The following is a description of a gene set: Genes down-regulated in CD8 T cells: naïve versus memory at day 30 after acute infection with LCMV-Armstrong. During acute viral infections, naïve CD8+ T cells differentiate into effector CD8+ T cells and, after viral control, into memory CD8+ T cells. Memory CD8+ T cells are highly functional, proliferate rapidly upon reinfection and persist long-term without antigen. In contrast, during chronic infections, CD8+ T cells become “exhausted” and have poor effector function, express multiple inhibitory receptors, possess low proliferative capacity, and cannot persist without antigen. To compare the development of functional memory T cells with poorly functional exhausted T cells, we generated longitudinal transcriptional profiles for each. studied in species Homo sapiens from publication Doering TA, Crawford A, Angelosanto JM, Paley MA, Ziegler CG, Wherry EJ (PMID 23159438) Human Gene Set: GSE41867_NAIVE_VS_DAY30_LCMV_ARMSTRONG_MEMORY_CD8_TCELL_DN, and this is the list of marker genes: POC5, MTO1, CWF19L1, PGM3, PAQR3, BOLA3, LONP1, EIF4H, FANCB, POLR2B, ZBTB32, AGK, VPS72, SGTA, POLR2K, RUFY1, PLEKHA3, PCMT1, TIPIN, SUMF2 (NCBI Gene Id 25870), API5, PDLIM1, PTBP1, KIAA1191, TAF1C, SLC25A1, RBMXL1, PSMD12, OLA1, RFK, MOSMO, RCCD1, LYRM1 (LYR motif containing 1), FMC1, BAG4, SETDB1, ATP23, PRORP, RCC2, CCDC51, CD44, ALG3, FBXO28, COPS2, DENND4C, LIG1, LRP6, PELP1, MSANTD4, UBE2G2, SDR39U1, LDAH, CFAP298, NETO2, DUS1L, FASTKD2, GCLC, PTPN12, PSMC1, CDC34, REPIN1 (NCBI Gene Id 96712), DHRS13, PCYT1A, SNRPD1, TRIP10, BOLA1, MPHOSPH8 (M-phase phosphoprotein 8), MAGOH, MMGT1, CCDC59, PREP, COX11, DNAJC27, FAM241A (family with sequence similarity 241 member A), CTNNAL1, NDUFS3, PINX1, NOL10, TXN, RBIS, PLXND1, DYNC1LI1, CDC73, BCAS2, NUP42, MARCKSL1 (MARCKS like 1), UBE2J2, AKR1B1, DDX19A, EMD, GAN, GPHN, ECE2, PTGES2, HAUS7, SLF1, MTF1, LTA4H (leukotriene A4 hydrolase), NPLOC4, TMEM147, SLC7A6OS, ANAPC4, ZNF490, DNAJA2, MCMBP, RINT1, RNMT, TANGO6, POM121, CDK17, CCDC171, EFTUD2, NIBAN1, KLHDC10, AMMECR1 (NCBI Gene Id 9949), CHORDC1, ME2, ADRA1A, HGH1, INTS8, SEMA7A, SGSM3, OTUD6B, OGDH (oxoglutarate dehydrogenase), SEC23IP, DUSP16, NAA10, POMP, POLR1F, ZWILCH, KPNA4, THAP4, DCPS, METRN, UBE2M, KLHDC9, CAND1, TBL3, CLPX, SLC25A32, HSPBP1, WDR89 (NCBI Gene Id 112840), SECISBP2, SMG8, NTPCR, LARP1, GPSM1, WEE1 (WEE1 G2 checkpoint kinase), C1orf50, GTF3C6, RDH13, NUBPL, NDUFS1, HMGA1, ORC5 (origin recognition complex subunit 5), KRI1, NT5DC3, MBD3, GEMIN8, TPRN, VCPKMT, SHQ1, ZNF213, COX10, CCNC, SCYL1, CIAPIN1, MRPS23, NUTF2, MCM10, MACIR, CAMSAP1, UQCR10, HDGF, LIPT1 (NCBI Gene Id 51601), ST3GAL2, PUS3, MCM5, FAM98B, DYM, ATP5F1A, UBE2N, PPIA, CST7, UBXN2B, MKLN1, PRDX6, DDX47, SLC19A2, HAX1, DPP3, ZC3H18, ETFB, CDC23, MRPL58, TTC4, MTG2, MAP3K7, MYD88